Given this list of marker genes RYR2, MDM2, TNNI3, NOG, MESP1, ZFPM2, POU4F1, SCN5A (NCBI Gene Id 652341), BMPR1A, PTK7, TRIP11 (thyroid hormone receptor interactor 11), MEF2C, MYL3, SMAD7, BMPR2, EGLN1, COL11A1, SUFU (NCBI Gene Id 51684), ROBO1, NKX2-5, MIR1-1, AP2B1, HEG1, TNNI1, TNNC1, HES1, NOTCH1, ZMPSTE24, SFRP2, SLIT2, GATA4, HEY2, KCNK2, TBX20, NACA, TGFBR1, TGFB2, ID2, SLIT3, APLNR, HAND2, ZFPM1, GSK3A, EDNRA, DAND5, TNNT2, NRG1, NPY5R, TBX5, LMO4, MYBPC3, MIR17HG, FZD2, PPP1R13L, MDM4, BMP10, SALL4, PRDM1, PTCD2, JAG1, RBM15 (RNA binding motif protein 15), PKP2, MATR3, LUZP1, HEYL, TGFB1, GJA5, HEY1, ISL1, NPY2R, FGFR2, MYH7, FOXC1, GREB1L, CITED2, TBX3, MYL2, RBPJ, MED1, CNTRL, HAND1, FKBP1A, XIRP2, CPE, STRA6, VANGL2, CCN1, ROBO2, HOXA13, FOXH1, UBE4B, TPM1, FOXF1, MYH6, GRHL2, SMARCD3 (SWI/SNF related, matrix associated, actin dependent regulator of chromatin, subfamily d, member 3), SOX11, WNT5A, NAGLU, CHD7, TGFBR3, DCTN5, DLL4, TMEM65 (transmembrane protein 65), FZD1, GATA3, HIF1A, SALL1, ENG, PITX2, SMAD6, BMP4, EVA1A, NSD2, TGFBR2, FRS2, SOX4, LRP2, NPRL3, PAX8, NOS3, FGFRL1, WNT11, HECTD1 (NCBI Gene Id 25831), SAV1, PDE2A, ACVR1, PROX1, SMAD4, FOXC2, SEMA3C, DSP, MYOCD, ADAMTS19, here is a description of the gene set: Human Gene Set: GOBP_CARDIAC_VENTRICLE_DEVELOPMENT studied in species Homo sapiens The process whose specific outcome is the progression of a cardiac ventricle over time, from its formation to the mature structure. A cardiac ventricle receives blood from a cardiac atrium and pumps it out of the heart.